The following is a description of a gene set: ER to Golgi Anterograde Transport Mouse Gene Set: REACTOME_ER_TO_GOLGI_ANTEROGRADE_TRANSPORT species: Mus musculus, and this is the list of marker genes: Tuba3b, Copg2, Trappc6a, Tubb4b, Copz1, Sec24d, Ykt6, Ins1, Sec31b, Capza2, Scfd1, Actr1a (NCBI Gene Id 54130), Sec24a, Nsf, Trappc9, Tuba1a, Cog5, Trappc1, Ppp6r1, Arf1, Golga2, Tmed7, Arf4, Dync1li1, Arfgap3, Sec23ip, Arf3, Cnih3, Mia2, Sptbn5, Ank1, Tmem115, Dctn6, Ankrd28, Arf5, Tmed9, Cd55, Gorasp1, Cog3, Stx17, Trappc2l, Golgb1, Lman2, Sptbn1, Copb1, Uso1, Dctn5, Tmed10, Bet1l, Kdelr3, Actr10, Cog8 (component of oligomeric golgi complex 8), Arfgap1, Napb, Sec16b, Trappc6b, Tmed3, Lman1l, Capzb, Rab1b, Tubb6, Copg1, Napg, Sptbn4, Sptbn2, Sptan1, Dync1h1, Dync1li2, Tuba4a, Sec23a, Trappc5, Tbc1d20, Bet1, Gosr1, Tubb3, Stx5a, Kdelr1, Cope, Preb, Csnk1d, Copa, Sec22c, Cog1, Dync1i2, Trappc10, Dynll1, Lman1, Tubb1, Cnih1, Spta1 (spectrin alpha, erythrocytic 1), Gria1, Mcfd2, Cog2, Ctsc, Tuba3a, Tubb2a, Sec16a (NCBI Gene Id 99224), Tuba1b, Dctn3, Kdelr2, Areg, Sec31a, Arfgap2, Copb2, Lman2l, Cd59b, Sptb, Sec13, Sar1b, Dynll2, Tubal3, Arcn1, Sec22b, Tgfa, Gosr2, Cog6, Ppp6c, Serpina1b, Sec22a, Cog4, Dctn4, Sec24c, Dctn2, Trappc4, F8 (NCBI Gene Id 14069), Ctsz, F5, Tuba1c, Napa, Trappc3, Trappc2, Cog7, Tmed2, Dctn1, Gbf1 (NCBI Gene Id 73518), Tubb4a, Rab1a, Capza3, Tfg, Copz2, Mia3, Cnih2, Ppp6r3, Tubb2b, Folr1, Sec24b, Dync1i1, Serpina1c, Tuba8, Col7a1